Given this list of marker genes Snx5, Pear1, Cdc42se2, Rac1, Abl2, Myo1g, Arhgap25, Trip10, Tnf, Sh3bp1, Bin2, Coro1a, Irgm1, Tlr4, Adgrb1, Clec4e, Syt11 (NCBI Gene Id 99745), Dnm2, Ager, Lcp1, Arhgap12, Aif1, Rab11fip2, Megf10, Rack1, Mcoln1, Pip5k1c, Abca7, Anxa1, Ticam2, Rab31, here is a description of the gene set: species: Mus musculus An invagination of the cell membrane formed by an actin dependent process during phagocytosis. Following internalization it is converted into a phagosome. Mouse Gene Set: GOCC_PHAGOCYTIC_CUP